Given this list of marker genes NMB, H2BC21, SOX4, EMILIN1, CDC25B, ZFP36, RGL1, TMEM158, DNM1, TNFAIP6, SREBF1, FASN, GAS6, SERPINB2, VEGFB, LY6E, GEM, CXCL3, TGFB1, CCL2, H2AC6, IER3, PLEC, H2AC18, KHSRP (KH-type splicing regulatory protein), HLA-F, TRIM16, MAFF, IRF9, PDPN, TFAP2C, STMN2, ENTREP3, SORBS3, DNM2, IL6, COL6A1, HSPA1A, MMP3, CKS2, PTGES, COL16A1, ZFP36L2, NAGPA, ENG, IFI30, ATP2B1, PLA2G4C, CD47, MMP1, HTRA1, MGRN1, TAPBP, FCHO1, AGRN, IRAK1, MAP2K2, CEBPB, SOD2, CXCL8, ANPEP, here is a description of the gene set: Genes up-regulated in normal fibroblasts in response to IL6. Human Gene Set: DASU_IL6_SIGNALING_UP from publication Dasu MR, Hawkins HK, Barrow RE, Xue H, Herndon DN (PMID 15095275) studied in species Homo sapiens The structural rearrangement of collagen fibres in hypertrophic scar causes abnormal contracture, low tensile strength, and raised scars, which cause functional impairment and disfigurement. It is hypothesized that changes in the genes of cytokines, extracellular matrix proteins, and proteins regulating programmed cell death are related to hypertrophic scar formation. To test this hypothesis, fibroblasts were cultured from hypertrophic scars and their response to interleukin-6 (IL-6) stimulation was studied by defining their gene expression profiles. Affymetrix gene chip analysis was used to identify up- or down-regulation in the genes present in the affymetrix array. RT-PCR and ELISA assays were used to validate microarray expression profiles further. Comparison of gene profiles showed an increase of genes in hypertrophic scar fibroblasts compared with normal skin fibroblasts, while the expression of genes decreased. Thirty-three genes were affected by IL-6 treatment in the hypertrophic scar fibroblasts, while genes were affected in normal skin fibroblasts. Messenger RNA to beta-actin ratios for matrix metalloproteinase-1 (MMP-1) and MMP-3 were increased with IL-6 in normal skin fibroblasts from 2.43 +/- 0.06 to 5.50 +/- 0.45 and from 0.75 +/- 0.09 to 1.98 +/- 0.01, respectively. No change in these matrix metalloproteinases could be shown with IL-6 stimulation in hypertrophic scar fibroblasts. Secreted protein levels of pro-MMP-1 and MMP-3 were elevated in the supernatants from normal skin fibroblasts from 2.00 +/- 0.09 and 1.72 +/- 0.10 ng/ml to 4.60 +/- 0.12 and 3.41 +/- 0.20 ng/ml, respectively, after treatment with IL-6 (p < 0.05). No changes were observed in hypertrophic scar fibroblasts treated with IL-6. Values are means +/- SEM. The absence of any up-regulation of MMP-1 and MMP-3 in hypertrophic scar fibroblasts, in response to IL-6, suggests that suppression of matrix metalloproteinases may play a role in the excessive accumulation of collagen formed in hypertrophic scars. While the pathogenesis of abnormal hypertrophic scars remains poorly understood, the use of gene expression arrays may prove helpful in identifying the mechanisms responsible for this type of abnormal scar formation and in formulating an effective therapeutic protocol.